The following is a description of a gene set: The series of molecular signals initiated by binding of a ligand to the tyrosine kinase receptor ERBB3 on the surface of a cell, and ending with the regulation of a downstream cellular process, e.g. transcription. ERBB3 receptors have impaired kinase activity and rely on the kinase activity of the heterodimer partner for activation and signal transmission. Human Gene Set: GOBP_ERBB3_SIGNALING_PATHWAY species: Homo sapiens, and this is the list of marker genes: RTN4, MAP2K1, ERBB3, MYOC, MAP2K2, MAPK3, ERBB2, RAF1, MAPK1, NRG1